The following is a description of a gene set: studied in species Mus musculus from publication Aprelikova O, Pace AJ, Fang B, Koller BH, Liu ET (PMID 11384963) BRCA1 gene is a tumor suppressor for breast and ovarian cancers with the putative role in DNA repair and transcription. To characterize the role of BRCA1 in transcriptional regulation, we analyzed gene expression profiles of mouse embryonic stem cells deficient in BRCA1 using microarray technology. We found that loss of BRCA1 correlated with decreased expression of several groups of genes including stress response genes, cytoskeleton genes, and genes involved in protein synthesis and degradation. Previous study showed that BRCA1 is a transcriptional co-activator of p53 protein; however the majority of p53 target genes remained at the same expression levels in BRCA1 knockout cells as in the wild type cells. The only p53 target gene down-regulated with the loss of BRCA1 was 14-3-3 sigma, a major G(2)/M checkpoint control gene. Similar to cells with decreased 14-3-3 sigma activity, BRCA1-deficient cells were unable to sustain G(2)/M growth arrest after exposure to ionizing radiation. We find that BRCA1 induction of 14-3-3 sigma requires the presence of wild type p53 and can be regulated by a minimal p53 response element. Human Gene Set: APRELIKOVA_BRCA1_TARGETS Genes down-regulated in embryonic stem cells with BRCA1 loss of function (LOF)., and this is the list of marker genes: ACTA1, GOT2, PSMC2, TUBA1A, SARS1, VIM, CKB, PDIA3, EIF3C, ANXA5 (NCBI Gene Id 308), DDX21, ATP6AP1, ACTA2, STAM, PEG3, TAGLN, CA2, NEFL, WARS1, FGFR1, DLG1, LXN (latexin), PSMC1, ARF1, APP, ID3, DDX3X, HSP90AA1, QKI, EIF2S1, EPRS1, SPTAN1, TPM1, NUMB, TFAP2C, ROCK2, SFN, RIT1, RPA2, FGFBP1, ANXA3, ACTC1, DNAJA1, WNT3, KRT8, HMGA2, DDX1, DDX24